Given this list of marker genes Cldn3, Ptma, Pgd, Cd63, Sycn, Snrpa, 2210016L21Rik, Nabp2, Hmgn1, Lsr, Noxo1, Aldh1b1 (NCBI Gene Id 72535), Tomm40, Rbm25, Elof1, Rgcc, H1f0, Frat1, Gipc1, Eif3k, Nfic, Bsg, Cdx2, Fgfbp1, Park7, Rbm42, Rps20, Gar1 (GAR1 ribonucleoprotein), Txn2, Sf3b4, Ier3, U2af1, Sdf2l1, Ppib, Krt18, Ccdc124, Vps72, Gadd45b (growth arrest and DNA-damage-inducible 45 beta), Ubl7, Swi5, Oaz1, Hes6, Mettl26, Cela1, Rps5, Sumo3, Foxa3, Ctrl, Pgp, Stub1, Sptssa (serine palmitoyltransferase, small subunit A), Rps18, Tkt, Selenow, Gm6402, H2az2, Nfkbib, Fam3d, Jund, Nubp1, Smagp, Cd151 (CD151 antigen), Psmg3, H2-K1, Rpl3, Ptgr1, Fahd1, Arl6ip4, Sfxn1, Eif3f (NCBI Gene Id 66085), Cltb, Bbc3, Mapk13, Gale, H2az1, Dcps, Cyba, Endog, Pkig, Npm3, Rps2, Pold4 (polymerase (DNA-directed), delta 4), Rps4x, Tmem14c, Osgep, Snrnp70, Pebp1, Gsta4, Sfn, Chmp2a, Akt1s1, Tex261, Mrpl38, Krt20, Pex11g, Lsm4, Mri1, Tubb5, Pafah1b3 (platelet-activating factor acetylhydrolase, isoform 1b, subunit 3), Znhit1, Nme2, Rps3a1, Ubb, Tmed4, Lamtor4, Psmd13, 2310011J03Rik, Sdsl, Klf13, Srsf7, Ppp1r1b, Fkbp2, Eif5a, Ybx1, Gnb1, Tomm6, Lsm2, Npm1, 1110004F10Rik, Ece1, Eif3g, H2ac23, Tmem160, Ssbp4, Adrm1, Rpl9, Arpc1b, Kcne3, Nudt22, Mrpl58, Psmc4, Snrpc, Guk1, Atp5mc2, Mrps18a, Ppp1r11, Bcl7c, Timm44, Krt7, Ube2e1, Ptov1, Hes1, Eif3i, Naa10, Mospd3 (motile sperm domain containing 3), H2-D1, Fth1, Cdc37, Stk16, Rpl13a, Babam1, Ctsh, Rbm3, Tmem234, Rpl4, Esrra, Selenom, Ap2s1, Gjb1, Hsp90ab1 (NCBI Gene Id 98078), Smco4, Rrp1, Uchl5, Efhd2, Mecr, Socs2, Hoxb6, Sox4, Krtcap3, Gatd3a, Hmgn2, Fbl, Slc25a3, Ly6e, Acta1, Rpl18 (ribosomal protein L18), Slc25a5, Sumo1, Mal (myelin and lymphocyte protein, T cell differentiation protein), H3f3b, Tmem9, Bri3, Akr1a1, Pla2g12a, Dctn3, Rnf186, Ranbp1, S100a14, Rpl7a, Tle5, Fkbp8, Arpc3 (actin related protein 2/3 complex, subunit 3), Rps9, Clu, Tmsb10, Cdc42ep5, Rfc2, Col1a2, Psmb4, Lamtor1, Mrpl28, Emc10, Antkmt (NCBI Gene Id 214917), Aarsd1 (NCBI Gene Id 69684), Cd248, Pllp, Rpl10a, Scand1, Trf, Smarcb1, Rpl13, Calm2, Rnase4 (NCBI Gene Id 58809), Pold2, Ftl1 (NCBI Gene Id 14325), Eef1b2, Eif6, Tbcb, Zfpl1, Ddrgk1, Zmat5, Apex1, Nt5c3b, Fam241b, Trp53, Erh, Szrd1, H2ax, Cox7a2l, 2610528J11Rik, Rsrp1, Rpl31-ps12, Trappc3, Gadd45gip1, Sdc4 (NCBI Gene Id 99320), Rpsa, Vcf1, Skic8, Rplp0, Vsig2, Hdgf, Raly, Lypla2, Ndufb7, Etfb, Phb2, Ostc, Gm9320, Lypd3, Mgst1, Rps6, Cd9, Clic1, Capzb, Akr7a5, Mfge8, Twf1, Tmem97, Prpf38b, Aamp, Cdx1, Wdr89, Hsd17b10, Csnk2b, Kdm6b, Ppy, Rgs1, Fermt1, Ifitm2 (NCBI Gene Id 80876), Serbp1, Emg1 (NCBI Gene Id 14791), Osr2 (NCBI Gene Id 93693), Srsf5, Cd81, Ninj1, Chchd10, Cdc123 (NCBI Gene Id 98828), Tmed3 (NCBI Gene Id 66111), Sdcbp2, Pmm1, Pibf1, Rpl11, Gpx4, Prr13, Nt5c, Tmed9 (transmembrane p24 trafficking protein 9), Nop56, Spint2, Car1, Copz1, Ier2, Ube2k, Psmc2, Cotl1, Spr, Tst, Ctsz, Set, Eef1d, Rps10, Gfus, Smim30, Mrto4, Acot8, Fdps, Wdr18, Tmem254, Eef1g, Map2k2, Ptpn6, Sgf29, Gsn, Sdhc, Tsen34, Prrg2, Tssc4, Mrps12, Ywhae, Kdelr1, Ptms, Mrps24, Trappc6b, Tecr, Asl, Exosc5, Atg101, Nme1, Dynll2, Wbp2, Pfn1, Sf3b2, Cdk4, Emc4, H1f2, Pkm, Drap1, Trappc6a, Ascl2, Aqp8 (NCBI Gene Id 11833), Hmgb1, Fam98c, Ppp4c, Pin1 (NCBI Gene Id 67670), Ccnd1, Emd, Retnlb, Laptm4a, Adh1, S100a16, Rack1, Hmg20b, Cfl1, Rps7, Pfdn6, Qtrt1, Cdpf1, Marcksl1, Rpl6, Manbal, Mtarc2, Rpl17, Efna4, Arpc4, Calm1, Psmd4, Cirbp, Manf, Rpl14, 2510002D24Rik, Cdk5rap3, Pglyrp1, Cfdp1, Stmn1, Arhgdia, Anp32b, Rps3, Pcsk6, Tff3, Naxd, Dhrs4, Akr1c12, Cdo1, here is a description of the gene set: studied in species Mus musculus from publication Tabula Muris Consortium (PMID 32669714) Mouse Gene Set: TABULA_MURIS_SENIS_LARGE_INTESTINE_INTESTINAL_CRYPT_STEM_CELL_AGEING